Given this list of marker genes Hrnr, Stfa3, Casp14, Krt10, Cdsn, Rptn, Csta1, Klk7, Sprr1a, Pkp1, Tgm3, Kazn (NCBI Gene Id 71529), Sprr2a3, Krt78, Sprr2d, Dsp, Ncl, Hspb1, Serpinb5, Anxa1, Klk6, Cstdc3, Krt77 (NCBI Gene Id 406220), Efr3a, Capn1, Sprr2b, Serpinb12, Stfa2, Sprr2a1, Jup, Lce1d, Krt16, Stfa2l1, Stfa1, Ivl, Ppl, Serpinb2, Krt75, Krt17, Krt2, Sprr2i, Sprr2e, Cstdc4, Lgals7, S100a9, Pkp3, Krt14, Sprr2k, Cst6, Cstdc6, Loricrin, Flg2, Cysrt1, Evpl, Anxa2, Sprr2h, Krt1, Cnfn, Cstdc5, Flg, Csta3, Lgals3, Sprr1b, Sprr2f, Krt5, Csta2, Sprr2g, here is a description of the gene set: A type of plasma membrane that has been modified through addition of distinct intracellular and extracellular components, including ceramide, found in cornifying epithelial cells (corneocytes). Mouse Gene Set: GOCC_CORNIFIED_ENVELOPE studied in species Mus musculus